Given this list of marker genes Aplp2, Ptges, Ctsg, Gstm5, Nav2, Acbd5, Dld, Sult1c1, Tpsb2, P2rx2, Pank3, Ndnf, Rspo2, Hpse2, Atp1a3, Apoh, Hnf4a, Nrp2, Gss, Gfra2, Mmachc, Slit2, Scp2, Selp, Angptl3, Ccn6, Ptn, Cd34, Nrtn, Sult1a1, Furin, Pf4, Ptges2 (NCBI Gene Id 96979), Tgfbr3, Vegfb, Chst15, Ftsj1, Agrn, H1f1, Ang6, P2rx1, Gcdh, Vegfa, Pcolce, Ccl5, Hadha, Fgf2, Fstl1, Ccn1, Ptprs, Fgf14, Cep104, Mcpt9, Prss34, Gstm2, Liph, Adgrg1, Aoc1l3, Mpo, Suv39h2, Gstm6, Impg1, Rtn4r, Acaca, Dmbt1, Sult2a1, Ccdc80, Col13a1, Impg2 (NCBI Gene Id 224224), Psg23, Lipc (lipase, hepatic), Sult2a7, Pnpla3, Eva1c, Vtn, Abi3bp, Gstm1, N6amt1, 2300002M23Rik, Pcolce2 (procollagen C-endopeptidase enhancer 2), Gstp3, Gstp1, Alas2, Rpl22, Fgf12, Eci3, Comp, Nrp1, Ogdh, Mdk, Ncam1, Ccl7, Hrg, Ccl8, Pdcd5, Gstm7, Gsta2 (NCBI Gene Id 14858), Col5a3, Slc6a6 (solute carrier family 6 (neurotransmitter transporter, taurine), member 6), Fn1, Itgam, Rcc1, Acadvl, Dbil5, Sfrp1, Fgfrl1, Ecm2, Pcif1, Bmp7, Cxcl10, Mettl3, Sult2a4, Tktl1, Ccn5, Prelp, Col11a1 (NCBI Gene Id 77655), Sost, Thbs1, Gnmt, Hmgcr (3-hydroxy-3-methylglutaryl-Coenzyme A reductase), Apoe, Cxcl11, Cbs, Gstm3 (glutathione S-transferase, mu 3), Chrd, Fst, Grem2, Sult2a2, Soat2, Fgfbp3, Tfb1m, Gsta5, Gstp-ps, Pcsk6, Ltc4s, Rspo4, Pla2g2d, Adgre5, Adamts8, Lgr4, Col28a1, Serpinc1, Sult2a8, Smoc2 (SPARC related modular calcium binding 2), Elane, Naa80, Fgfr1, Hmgb1, Acads, Eci2, Hmgcl, Mgst2, Ccn3, Ang2, Insr, Tktl2, Aoc1l1, Pank1, Fgf9, Pitpna, Lrpap1, Adamts15, Acadl, Ilvbl, Mgst1, Ltbp2, Mettl5 (methyltransferase 5, N6-adenosine), Gsr, Sult2a3, Fbln7, Serpine2, Gstm4 (glutathione S-transferase, mu 4), Psg17, Ang5, Alk, Ccl2, Ptch1, Thbs2, Acat1, Cxcl13, Sult2a6, Cfh, Rspo3, Mettl14, Ambp, Mettl17, Bsph2, Acbd6, Glra1, Ang, Serpina10, Prmt1, Fgf7, Hlcs, Thbs3, Ust, Fgf1, Nell2, Ccn2, Ppia, Aoc1l2, Sema5a, Tmem184a, Cma2, Rpl29, Fgfr2, Acadm, Fgfr4, Kmt5b, Dbi, Gsta1, Apoa5, Tsr3, Lancl1, Gsta13, Acacb, Thbs4, Hdgf, Acbd7, Igfals, Acbd3, Lamc2, Pcx, Mocs1, Hbegf, Lipg, Lxn, Mstn, Defb15, Lrrtm4 (leucine rich repeat transmembrane neuronal 4), Slit1, Dbt, Clec3b, Col23a1, Colq, Crispld2, Gstp2, Soat1, Zcchc4, Acot7, Aoc1, Glycam1, Lpl, Ptprc, Hacl1, Bmt2, Smoc1, Ccn4, Adamtsl5, Col5a1, Setd6, Tnxb, Apob, Serpind1, Dpysl3, Fgf10, Bmp4, Reg4, Slit3, Gpnmb, Postn, Twsg1, Cfhr2, App, Ltf, Pdcd5-ps, F11, Prss57, Aplp1, Tpmt, Nell1, Tkt, Dhtkd1 (dehydrogenase E1 and transketolase domain containing 1), Sult2a5, Tmem120a, Tpk1, Kmt5c, Rtn4rl1, Col25a1, Smad4, Defb34, Saa1 (serum amyloid A 1), Prmt8, Cfhr4, Ang4, Lipi, Adamts5, Pla2g5, Grem1, Bsph1, Gns, Adamts1, Tnfrsf11b, Ryr2, Mmp7, F2, Hsd17b12, Ptprf, Rspo1, Zfp207, Fbn1, Efemp2, here is a description of the gene set: Binding to a sulfur compound. Mouse Gene Set: GOMF_SULFUR_COMPOUND_BINDING species: Mus musculus